The following is a description of a gene set: Human Gene Set: GSE17721_0.5H_VS_4H_PAM3CSK4_BMDC_DN Genes down-regulated in comparison of dendritic cells (DC) stimulated with Pam3Csk4 (TLR1/2 agonist) at 0.5 h versus those stimulated at 4 h. from publication Amit I, Garber M, Chevrier N, Leite AP, Donner Y, Eisenhaure T, Guttman M, Grenier JK, Li W, Zuk O, Schubert LA, Birditt B, Shay T, Goren A, Zhang X, Smith Z, Deering R, McDonald RC, Cabili M, Bernstein BE, Rinn JL, Meissner A, Root DE, Hacohen N, Regev A (PMID 19729616) species: Homo sapiens mouse primary BMDCs were stimulated with tlr ligands and gene expression changes were profiled on Affymetrix arrays, and this is the list of marker genes: LTN1, RAD23B, MAP3K2 (mitogen-activated protein kinase kinase kinase 2), IL1RL2, SLC6A12, PARP8, ZNF207, ECI2, ITGA8, ASAP1, BTF3L4, ERGIC2, FKBPL, TPBG, PLAAT3, TBC1D1, TBK1, SLFN12L, LHX9, SEPHS2, M6PR, GALNTL5, FAM184B, SRP54, MAPKAPK2, COPG1, RCL1 (NCBI Gene Id 94533), VPS26A, DDX42, SAMD8, USB1, ENDOD1, SLC4A2, SPON1, BLOC1S4, EMC2, AZIN1, CPN1 (NCBI Gene Id 1369), C11orf91, SLC4A7, F10, SEC13, RFFL, GBP2, LACTB2, NAA15, ABRACL, SMOC2, ZWINT, CARMIL1, SGMS1, NNAT, LRRK2, KICS2, SDC4, TNNT2, MGAT2, BCDIN3D, SGO1, ZNF22, RPL24, MAP3K7, TUSC3, RNASET2, APLP2 (amyloid beta precursor like protein 2), CHORDC1, STYX, PTPRB, BHLHE41, YTHDC1, MFSD1 (major facilitator superfamily domain containing 1), WSB1 (NCBI Gene Id 26118, WD repeat and SOCS box containing 1), NCK1, FMNL3, NDUFA7, SRXN1, SFPQ, PSPC1, LPP, SSPN, BRAF, RAB2A, EIF1B, USP38, JDP2, TDRD1, RNF121, CRK, NR1H3, C14orf180, MNX1, HSD17B13, GBGT1, MOB1B, PSMD14, NDE1, CNTN4, GPR155, ZDHHC12, MYO10, SERINC1, RBM25, TAL2, OTUD4, NID1, KIF5C, KRT25, NEDD1, LHX2, BCL9, ITIH3, CD80, RASA2, RBFOX2, MMP17, SNAPC3, SLC25A17, STEAP1, GSTA3, RSRP1, UPP1, LRRC26, ATF2, BRWD1, ELAVL1, NEUROG3, RHOT1, COG4 (component of oligomeric golgi complex 4), BMP6, GATAD2A, NCOA2, CHRNG, WASHC4, GFPT1, EIF3E, KCTD1, PIPOX, ATF4, RIOX2, FBXO33, TEAD2, DYNC1LI1, PLSCR1, UBE2W, BCL7C, TMEM128, TSHZ2, PSME3IP1, CDV3, DAO (D-amino acid oxidase), CAPZA1, AOAH, PGLYRP2, PWP1, PHF3, PTPN1, ACOX3, PPP2CB, JAK1, FAAH, EDN1, YME1L1, GOPC, RGS5, LIN7C, TMEM143, RB1CC1, EXTL3, PKP4, DPPA2, GBE1, PFKP, PPP6C, ZFYVE16, RPS2, SUGT1, SRSF1, VPS35, SOCS1, TCF3, LSS, DDA1, IL2RG, CD70 (CD70 molecule), PLEKHO2, PRPF38A, C16orf87, RNF19A, MAP4K3, VCP, ITSN1, DAPK3, TANC1, POP7, MTURN, FAR1, RNF13, VAPA, YY1, GRAMD1A